The following is a description of a gene set: studied in species Mus musculus Mouse Gene Set: GOBP_BRADYKININ_CATABOLIC_PROCESS The chemical reactions and pathways resulting in the breakdown of the peptide bradykinin., and this is the list of marker genes: Ide, Mme, Ace, Cpn1, Xpnpep1, Ctsh, Ece1